Given this list of marker genes RORA, ACP5, ID1, FAH, ADAM1A, LARGE1, TBC1D22B, ADAP2, GABBR1, TICAM2, PCDHB13, MED16, BLOC1S6, TTC9C, SIGMAR1, SREBF1, SSX9P, TNFRSF13C, ICOSLG, PIM3, KLF6, HDAC1, CYP27A1, HCK, CLIC5, NTMT1, MVP (NCBI Gene Id 9961), FGF23, PTPN1, CRIM1, CDHR5, KCTD13, SLCO3A1, PLAAT3, SEMA7A, CH25H, MYBL2, GYS1, KIF1C (NCBI Gene Id 9713), KLF10 (KLF transcription factor 10), ACLY, ANGEL1, CD200, ENO3, SNX8, PSMB10, MTUS1, INTS9, AP2S1, PHLDA3, NET1, ITM2C, PTGIR, PDE1B (NCBI Gene Id 5153), CXCL11, HDAC5, CD86, ACVRL1, GPR33 (G protein-coupled receptor 33), ASAH2, PPARD, RNF32, ELF4, DIP2A, ATP6V1G3, LIN28B, UBTD1, HIBADH, IL12B, ENTPD1, SHISA6, TNFSF10, P2RX7, TNFRSF18, NCOA1, SLA, PLA2G15, XKR8, KLRC3, RNASEH2A, TMPRSS11F, MAX, AADAC, STXBP1, DBNL, SGO1, TMEM178A (transmembrane protein 178A), NDUFS2, AXL, LGMN (legumain), SASH3, TYK2, LRRC8A (NCBI Gene Id 56262), ZBTB17, CALHM6, FNDC3B, WFS1, MYD88, MUC19, RGS16, TEX11, IGFL3, ST3GAL5, MFHAS1, GCK, COTL1, MFGE8, CDH5, CALCR, BASP1, SERPINE1, ARL4C, MIR137, FYN, SPRR2D, KIF3B, PIK3AP1, CSRP1, IL5, DNASE1L2, GATM, PLA2G4A, TSC22D1, CHTF8, RHOH, DSE, ACSBG2, SLC25A19, MPP2, PGK2, NCLN, PHF19, IL1RAPL2, CIAO2B, PPP1R3B, SERTAD1, ABTB1, RAVER1, UNK, RCOR2, CIMIP2B, FIS1, ALMS1, PHF2, ASB11, KLHL18, MARCO, here is a description of the gene set: Genes up-regulated in B lymphocytes: control versus CpG oligodeoxynucleotide 1826. from publication Busconi L, Bauer JW, Tumang JR, Laws A, Perkins-Mesires K, Tabor AS, Lau C, Corley RB, Rothstein TL, Lund FE, Behrens TW, Marshak-Rothstein A (PMID 18025183) We have previously shown that rheumatoid factors (RF) produced by Fas-deficient autoimmune-prone mice typically bind autologous IgG2a with remarkably low affinity. Nevertheless, B cells representative of this RF population proliferate vigorously in response IgG2a/chromatin immune complexes through a mechanism dependent on the sequential engagement of the BCR and Toll-like receptor 9 (TLR9). To more precisely address the role of both receptors in this response, we analyzed the signaling pathways activated in AM14 B cells stimulated with these complexes. We found that the BCR not only serves to direct the chromatin complex to an internal compartment where it can engage TLR9 but also transmits a suboptimal signal that in combination with the signals emanating from TLR9 leads to NF-kappa-B activation and proliferation. Importantly, engagement of both receptors leads to the upregulation of a group of gene products, not induced by the BCR or TLR9 alone, that include IL-2. These data indicate that autoreactive B cells, stimulated by a combination of BCR and TLR9 ligands, acquire functional properties that may contribute to the activation of additional cells involved in the autoimmune disease process. species: Homo sapiens Human Gene Set: GSE6674_UNSTIM_VS_CPG_STIM_BCELL_UP